Given this list of marker genes CCN2, IGFALS, IGFBP4, INSR, IGFBPL1, IGFBP2, ITGA6, ITGB4, IGFBP3, IGFBP6, IGF2R, IGFBP1, IGFBP5, IGF1R, LRP2, ITGAV, KAZALD1, IGFBP7, ITGB3, here is a description of the gene set: studied in species Homo sapiens Human Gene Set: GOMF_INSULIN_LIKE_GROWTH_FACTOR_BINDING Binding to an insulin-like growth factor, any member of a group of polypeptides that are structurally homologous to insulin and share many of its biological activities, but are immunologically distinct from it.